The following is a description of a gene set: electronically inferred by orthology from the curated human pathway Reactome Pathway: Nuclear Receptor transcription pathway This event has been computationally inferred from an event that has been demonstrated in another species.<p>The inference is based on the homology mapping from PANTHER. Briefly, reactions for which all involved PhysicalEntities (in input, output and catalyst) have a mapped orthologue/paralogue (for complexes at least 75% of components must have a mapping) are inferred to the other species. species: Mus musculus part of: Generic Transcription Pathway, and this is the list of marker genes: Rxrb, Esrrb, Rarb, Nr2f6, Ar, Nek4, Nr2f1, Med1, Rorc, Esrrg, Rarg, Nr1h4, Hnf4a, Nr4a1, Nr2c2, Vdr, Nr3c1, Rorb, Nr0b2, Nr0b1, Esr1, Nr4a3, Thrb, Nr5a1, Nrbf2, Pparg, Nr2e1, Rara, Nr4a2, Hnf4g, Esr2 (NCBI Gene Id 13983), Rxrg, Ncor2, Nr1i2, Nr1d2